The following is a description of a gene set: studied in species Homo sapiens Reactome Pathway: lestaurtinib-resistant FLT3 mutants part of: Drug resistance of FLT3 mutants Lestaurtinib is a first-generation, type I tyrosine kinase inhibitor with activity against a range of receptor tyrosine kinases including FLT3. This pathway describes FLT3 mutants that are resistant to lestaurtinib-mediated inhibition., and this is the list of marker genes: FLT3